Given this list of marker genes Zfp704, Sos1, Cdadc1, Aak1, Ube3a, Sorl1, Gab1, Has3, Kbtbd2, Kif5a (kinesin family member 5A), Npas2, Tafa1, Caprin2, Rasgrf2, Pde12, Psd3, 6430548M08Rik, Acer2, Man1c1, Nabp1, Ankib1, Limk1, Cdk2, Ubxn8, Chmp4c, Prdm8, Fbxl5, Zbtb4, Mybl1, Csnk1g1, Pxk, Tspyl2, Lamp2, Spred1, Tmcc3, Golga1, Tnf, Map1b, Sobp, Nckap5, Rab5c, Ndel1 (nudE neurodevelopment protein 1 like 1), Fastk, Kmt2b, Pdgfra, Slain1, Snx5, Heg1, Arap2, Map3k9, Spopl, Kcnn2, Oxsr1, Ago1 (NCBI Gene Id 286948), Spty2d1, Garem1, Mier1, Gcc2, Prr14l, Btg1, Zhx2, Rad51b, E2f2, Wee1, Rnf216, Map3k12, Dcbld2, Afg1l, Hif1an, Cfl2, Arid4a, Fstl5, Phtf2, Pitpna, Znrf3, Pdik1l, Yaf2, Trp63, Ddhd2, Pcsk5, Tsn, Smoc2, Kdm2a, Tnks1bp1, Arhgef11, Ppp2r1b, Znfx1, Abhd3, Btbd10, Nfib, Crybg3, Irf2bp2, Pkd2, Zfp661, Fzd6, Wasf1, Rfx5, Rnf2, Fcho2, Arhgap29, Larp4, Pthlh, Mapk8, Zbtb18 (zinc finger and BTB domain containing 18), Elk4, Cast, Stxbp5l, Ppp1r15b, Frmd6, Bmpr2, Mex3d, Neurog3, Kcnk10, Cnot6, Crppa, Il25, Dennd10 (DENN domain containing 10), Lclat1, Btf3l4, Zfhx4, Mosmo, Tbc1d12, Usp32, Tesk2, Tox3, Sh3pxd2a (SH3 and PX domains 2A), Erbin, Suv39h1, Becn1, Mapk1, Naa30, Cmpk1, Synpo2, Rasl11b, Rb1, E2f7, Frrs1l, Dpysl2, Kcnd2, Cnot6l, Slc24a2, Nfia, Tgfbr2, Zbtb41, Itgb4, Dnajb9, Map7, Rorb, Gid4, Reps2, Mtmr4, Mbnl1, Sorbs2, Sumf1, Mylk, Hivep2, Mup20, Emx2, Adipor2, Miga2, Bbx, Arx, Jakmip1, Map3k2, Arhgap12, Sash1, Arhgap1, Fgf9, Skida1, Tapt1, Insyn2b, Gabrr1, Kmt2a, Tfap4, Slc40a1, Chd9, Polq, Myocd, Lmx1a, Atxn1l, Hs3st5 (NCBI Gene Id 382362), Prdm16, Fibin, Zfp11, Arid4b, Ankrd10 (NCBI Gene Id 74590), R3hdm1, Nhlh2, Itpr1, Rictor, Nipa1, Usp3 (ubiquitin specific peptidase 3), Cnot7, Asxl2, Lrig1, Gpr137c, M6pr, Cyyr1, Grb10, Rasd1, Tspan9, Ezh1, Prkaa1, Kcna1, Zfp367, Cds1, Tmem170b, Topors, Tanc2, Btbd7, Tbc1d15 (TBC1 domain family, member 15), Stx6, Panx2 (pannexin 2), Ptgfrn, Wdfy3 (WD repeat and FYVE domain containing 3), Ppp1r9a, Laptm4a, Atg16l1, Smad5, Cul3, Cep120, Smoc1, Rufy2, Elk3, Tbcel, Plcb1, Hbp1, Zfand4, Pafah1b1, Nat3, Acsl4, Skil, Dcaf8, Myrf, Bmt2 (NCBI Gene Id 101148), Hs3st3b1, Apcdd1, B3galt2, Cpeb1, Mbnl3, Psd, Ikzf2, Ccdc88a, Ankrd44, Slc25a36, E2f1, Blcap, Pdzd7, Erbb4, Cldn8, Klhl20, Vwde, Tnfrsf21, Jmy, Casd1, Rtn1, Pgm2l1, Sema7a, Zfp91, Nrp2 (neuropilin 2), Bnc2, Actl6a, Atl3 (atlastin GTPase 3), Arhgap6, Sfmbt1, Atp2c1, Hoxa3, St6galnac3, Plekha3 (NCBI Gene Id 83435), Aldh1b1, Mup3, Mfsd6, Mtbp, Stk17b, Map3k8, Snrk, Hey2, Jak1, Bnip2, Zfp286, here is a description of the gene set: Genes predicted to be targets of miRBase v22 microRNA mmu_miR_350_5p in miRDB v6.0 with MirTarget v4 prediction scores > 80 (high confidence targets). Mouse Gene Set: MIR_350_5P from publication Chen Y, Wang X (PMID 31504780) studied in species Mus musculus